Given this list of marker genes Rgs2, Adgrv1, Gnai1, Gnaz, Grm7, here is a description of the gene set: Mouse Gene Set: GOMF_ADENYLATE_CYCLASE_INHIBITOR_ACTIVITY studied in species Mus musculus Binds to and decreases the activity of adenylate cyclase.